Given this list of marker genes H2AC25, EPDR1, MVB12B, MGAT5, NUF2, XPOT, PARP1, RYK, ELOVL6, GLCCI1, TAF2, DBF4, FOXK2, OCA2, FAM83D, PREX2, MICAL1, SLC4A2, GPC6, TYR, SLC35C2, BLM, ATP6V0A1, VGLL3, WDHD1, DARS2, PARVB (parvin beta), GSTP1, MAPK3, BCKDK, RAD23B, SMTNL2, MCM10, SMAD5, FUBP3, ADGRG1, DLGAP5, PBX3, CUBN, ING3, PPP6R2, ATAD5, RHBDD2, IPO8, SMPD4, WWC1, H2AZ1, PIGU, MAD2L1, ANO3, PCBP4, UFSP2 (NCBI Gene Id 55325), VDAC1, KLHL13, POC1B, GTSE1, PIK3R3, POGLUT2, LIMA1, ANAPC5, BDH1, SLC30A9, PRKAG2, ARL2BP, GINS1, UBR1, FRMD3, BCAT1, ABCA12, KIRREL1, ALG3, CERS5, PMPCA, MAN2A2, KNL1, KLHDC10, PRIM1, PLEKHA3, IQGAP3, ARHGAP39, SLC25A10, TNPO3 (transportin 3), POLD2, UTP20, TCF7, ANO6, TMEM184C, SIGMAR1, CNTFR, PRKAA1, FANCD2 (FA complementation group D2), PDK1, ASF1B, PAPSS1, ARL8B, C2CD2L, ANTXR1, EXO1, SORT1, GXYLT2, OXNAD1, DUSP3, SLC6A6, TUBGCP3, MRPL37, CDC42BPA, CDC14B, ACAD9, ARSB, PGAP3, NBEA, TRAF4, PLA2G6, EPHX1 (epoxide hydrolase 1), PEG10, LDLRAD3, LMNB2, AMZ2, SLC38A1, H2AZ2 (H2A.Z variant histone 2), CDCA2, EIF3L, POMT1, TRMT1, B3GLCT, DAD1, TOB1, NFYC, CUTA, PTGR1 (NCBI Gene Id 22949), SLC35A4, POMGNT1, UBQLN4, DTYMK, PIP5K1C, CKS2, PPT2, MOSPD3, CLPTM1, TOM1L2, RAB18, L3MBTL2, DHCR24, PTP4A3, MCC, RTEL1, POLE2, MBP, DEPDC5, MCM8, AKT1, CIT, MAPK1 (NCBI Gene Id 5594), TRIM24, TMEM97 (NCBI Gene Id 27346), RNF170, IPO9, CBX5, AGO1, SGIP1, GRIA4, SLC6A17, WEE1 (NCBI Gene Id 7465), PRODH, SCAP, ARHGAP6, OXA1L, FADS2, TTC7B, RAF1, GTF2IRD1, CHEK2, TOMM40 (translocase of outer mitochondrial membrane 40), IDH2, TCN2, BUB1B, TMEM106B, FECH, ZDHHC4, ITGA9, STRBP, BAG6, CKAP2L, RAB34, KIF2C, RASGRP3, SPRY4, here is a description of the gene set: IgG cytoplasmic tail interferes with the induction of antigen-response genes from publication Horikawa K, Martin SW, Pogue SL, Silver K, Peng K, Takatsu K, Goodnow CC (PMID 17420266) species: Homo sapiens Human Gene Set: GSE7218_UNSTIM_VS_ANTIGEN_STIM_THROUGH_IGG_BCELL_UP Genes up-regulated in B lymphocytes: expressing IgM BCR fusion and untreated versus expressing IgMG BCR fusion and treated by anti-HEL.